The following is a description of a gene set: Human Gene Set: HP_BRUISING_SUSCEPTIBILITY studied in species Homo sapiens An ecchymosis (bruise) refers to the skin discoloration caused by the escape of blood into the tissues from ruptured blood vessels. This term refers to an abnormally increased susceptibility to bruising. The corresponding phenotypic abnormality is generally elicited on medical history as a report of frequent ecchymoses or bruising without adequate trauma. Bruising susceptibility, and this is the list of marker genes: NABP1, B3GALT6, TGFB2, PRF1, COL5A1, ARMC5, PML, FOXE3, THBS2, SOS1, WAS, SLC2A10, FUCA1, ITGB3, F8, FANCD2, SIK3, CASP10, TET2, MAPK1, COL5A2, FAS, ENPP1, FGA, TGFB3, MYH9, PYCR1, NFIX, DTNBP1, PLEC, WIPF1, CBL, FLNA, RASGRP2, COL1A2, RASA2, ZBTB16, RRAS, FANCC, GGCX, CHST14, SPRED2, TP53, NUMA1, CREB3L1 (cAMP responsive element binding protein 3 like 1), PRKG1, NBEAL2, AIP, MYH11, MCFD2, GNE, LMAN1, GNAS, GP9, USP48, CLCN7, IPO8, ADAMTS2, SNX10, TBXA2R, HEY2, MFAP5, BCOR, ELN, UNC13D, PRKAR1A, FGG, FIP1L1, SOS2 (SOS Ras/Rho guanine nucleotide exchange factor 2), HBA2, SMAD3 (SMAD family member 3), LOX, MRAS, FASLG, TNXB, SCARB2, FBN1, DSE, SMAD4, P2RY12, VWF, RIT1, ATP7B, FCGR2C, HPS6 (HPS6 biogenesis of lysosomal organelles complex 2 subunit 3), RUNX1, STX11, PLOD1, MTAP, F2, MYLK, HBA1, C1R, TPM4, SMAD2, STAT3, HPS3, KDM1A, MAP2K1, F10, PRDM5, RRAS2, CDH23, HPS4, PLAU, LZTR1, TGFBR2, ATRX, EFEMP1, THSD4, TNFSF11, F5, GSN, PTPN11, ZNF469, GP6, ACTA2, NPM1, GP1BA, COL3A1 (collagen type III alpha 1 chain), AEBP1, MAT2A, ETV6, FGB (NCBI Gene Id 2244), F13B (NCBI Gene Id 2165), BLOC1S5, COL1A1, STXBP2, RAF1, TCIRG1, C1S, ABCC6, EMILIN1, ATP7A, GFI1B, GATA2, HPS5, F13A1, NR3C1, SLC51A, KRAS, F7, GBA1, STIM1, BRAF, IRF2BP2, SERPINF2, FANCA, BLOC1S3, FANCE, RARA, SLC37A4, NTRK1, STAT5B, PDE11A, CALR, TBL1XR1, BGN (NCBI Gene Id 633), JAK2, USP8, HPS1, PTPRJ, APOA1, GP1BB, TGFBR1, F9, NRAS, LYST, SLC39A13, PRKACA, SH2B3, PLOD3, FKBP14, GATA1, ANKRD26, TNFRSF1A, MPL, RIN2, ITGA2B, SLFN14